Given this list of marker genes Zfp800, Fzd3 (frizzled class receptor 3), Rab32, Myo18a, Pgm2l1, Bicd2, Nfat5, Vsnl1, Gpcpd1, Ttc28, Myh10, Sar1b, Ifnar1, Kcns3, Dapp1, 4930402K13Rik, Arfgef3, Eeig1, Agbl2, Synpo, Otor, Ipmk, Scn3b, Cyth1, Brms1l, Slc1a2, Car10, Slc31a1, Slc25a36, Slain2, Ccn4, Dip2c, Dsg1b, 6430571L13Rik, Zfp706, Rer1, Arhgap19, Ror1, Ccdc71l, Stxbp1 (NCBI Gene Id 98927), Rab17, Fign, Rc3h1, Efcab14, Wdr76, Nckap1 (NCK-associated protein 1), Itih5, Atrx, Prickle2, Ap3s1, Hipk3, Atf3, Noto, Ammecr1l, Rassf4 (Ras association (RalGDS/AF-6) domain family member 4), Cdc27, Xbp1, Ubqln2, Asxl2, Trappc3, Sestd1, Gopc, Rbm41, Ate1, Leprotl1, Sec61a1, Arpc5, Phlpp1, Sprr2f, Mtmr3, Rfx1, Nsun5, Tspoap1, Rasef, Gucy1a2, Mrpl53, Larp4, Tmem164, Maml2, Dcp1a, Isx, Dnajc27, Zfp119b, Plekhh1, Clta, Ubap2, Dcc, Tiparp, Cdkn2c, Il15ra (NCBI Gene Id 98822), Med13, Cobl, Taf5, Cfl2, Zbtb34, Zfp28, Mbtps2, Zic1, Col7a1, Tmem100, Card6, Tcf7l2 (transcription factor 7 like 2, T cell specific, HMG box), Nr3c1, Vasn, Mtcl1, Vgll3, Clock, Sidt2, Mphosph9, Lrba, Atad1, Ddx3x, Ppfia3, Ccdc88a (coiled coil domain containing 88A), here is a description of the gene set: Mouse Gene Set: MIR_674_5P from publication Chen Y, Wang X (PMID 31504780) studied in species Mus musculus Genes predicted to be targets of miRBase v22 microRNA mmu_miR_674_5p in miRDB v6.0 with MirTarget v4 prediction scores > 80 (high confidence targets).